Given this list of marker genes AP3S1, HSPB2, FUZ, MORN3 (MORN repeat containing 3), POLR3K, IDO1, BUB1B, IFITM10, NUDT22, ZNF474, UBE2S, ARF5, KCNE3, LY6G6C, BSND, TACC3, WBP4, WDR70, MSRB1, RGR, CCDC88C, CREB3L3, SHROOM1, GJB2, RBBP8, SCTR, ANKRD6, MEP1B, SNRPB2, SAP30, MAT1A, MARCO, C17orf99, LSM12, EIF4A1, GPR27, APOH, SNX9, SMARCA5, EPHX4, C7orf50, TEKT2, CDK2AP2, MT3, GTSF1L, GCM1, NCAPG, FOXN4, NFKBIB, HSPBAP1, B3GNT4, CNGA1, SERPINB12, EIF1AD, ZNF786, STOML3, AKAP14, AJAP1, CORT, MCM4, PI15, GTSE1, SNRNP35, PELO, GEN1, NUP188, AKAP6 (A-kinase anchoring protein 6, NCBI Gene Id 9472), TMEM192, ADARB2, LACTBL1, SLC26A7, HHATL, ATG9B, APOM, LRP8, LIMCH1, SRD5A3, REG4, NPM3, LY6H, NXT1, ZDHHC15, USP14, ERCC6L, CYP17A1, GP2, PSMD13, TPCN1, NRG3, DBN1, ADRA2C, DGKE, NDC80, SLC15A4, ADAM17, C6orf118, PRIM2, DGKB (diacylglycerol kinase beta), CFAP69, ALDH1A2, WASF3, SIGMAR1, TBCK, VSIG1 (NCBI Gene Id 340547), CNN3, PEPD, CHRDL2, PRR11, DTL, MYT1L, CYLC2, LTBP1, SPAG5, TEKT3, FAM216B, KNSTRN, PIGV, TMC8, MCM3, ETNPPL, TCAP, SNRPF, RAD51AP1, KIF1C, ASS1, RASD2, SDF2L1, SRPK3, SLC7A13, CTSB, ADRA1B, ZNF446, DICER1, ECT2, METTL6, PLIN5, HSPA8, SRSF9, CEL, TRIP13, CDK5RAP2, NMRK2, SP5, SLIT1, RAB30, JMJD7-PLA2G4B, IL31RA, MAOA, SLC1A6, CD40LG, PDIA4, ZNF830, NIN, RBP7, SUZ12, TP73, NUBP1, HOXB13, GDF15, BRINP1, SMIM12, MCM6, STRA6, FOXN2, DDOST, OPN1LW (NCBI Gene Id 8261), NAA16, ZGLP1, NCAPD2, LAMP1, PTH2, PMFBP1, MAD1L1, CDA, MB (myoglobin), MDM1, BNIPL, TXNDC11, ERP29, SEMA3B, PGAM2, SMARCE1, CLEC3B, NF1, CYP2B6, NME8, PCNX2 (NCBI Gene Id 9845), NT5E, UBE2C, FBLN2, NUP107, CUBN, NEFL, LDHC, WDR76, GORASP2, SVIP, ADORA2B (NCBI Gene Id 136), CARF, NCLN, here is a description of the gene set: STAT3, an essential transcription factor with pleiotropic functions, plays critical roles in the pathogenesis of autoimmunity. Despite recent data linking STAT3 with inflammatory bowel disease, exactly how it contributes to chronic intestinal inflammation is not known. Using a T cell transfer model of colitis we found that STAT3 expression in T cells was essential for the induction of both colitis and systemic inflammation. STAT3 was critical in modulating the balance of T helper 17 (Th17) and regulatory T (Treg) cells, as well as in promoting CD4+ T cell proliferation. We used chromatin immunoprecipitation and massive parallel sequencing (ChIP-Seq) to define the genome-wide targets of STAT3 in CD4+ T cells. We found that STAT3 bound to multiple genes involved in Th17 cell differentiation, cell activation, proliferation and survival, regulating both expression and epigenetic modifications. Thus, STAT3 orchestrates multiple critical aspects of T cell function in inflammation and homeostasis. studied in species Homo sapiens Genes down-regulated in CD4 T cells: IL6 versus TGF beta and IL6. Human Gene Set: GSE21670_IL6_VS_TGFB_AND_IL6_TREATED_CD4_TCELL_DN from publication Durant L, Watford WT, Ramos HL, Laurence A, Vahedi G, Wei L, Takahashi H, Sun HW, Kanno Y, Powrie F, O'Shea JJ (PMID 20493732)